Given this list of marker genes YWHAEP7, CCL20, ZNF318 (NCBI Gene Id 24149), CCDC51, RPL34P29, ARHGAP24, POU6F1, DSP, UBE3C, MOGAT3, CSAD, EFNA1, GMNN, TSSC4, CCDC191, METTL25, SLC16A13, FBXO38, SGK1, ZYX, ARHGEF2-AS1, LINC03064, M6PR, PXN-AS1 (PXN antisense RNA 1), SNRPB (small nuclear ribonucleoprotein polypeptides B and B1), EIF4A2, SYBU, COG8, HMGN2P46, PPFIA3, LMO7, LNCRNA-IUR, SNORD2, ZKSCAN2, LDLRAD4, LINC02428, ENO1-AS1 (NCBI Gene Id 100505975), GNG4 (NCBI Gene Id 2786), GPD2, GTPBP3, MMADHC, TTR, SEPTIN2, SESN3, SLC8A1-AS1, BCL9, CCDC28A-AS1, RREB1, LAPTM4A, TMEM217, NDUFS2, CACYBP, FMC1, SUMF2, TIMELESS, ENC1, DDX50, PDGFRB, SWT1, ZBED5-AS1, TOR1AIP1, SLC39A4, C10orf88, SYPL1, WNK4, UBE2D3, TANK-AS1, SIRT6, ZGRF1, LRRC42, MRPS15, SLC25A25, NDUFAF1, CERT1, MIR3912 (NCBI Gene Id 100500831), CCDC59, SCAPER, SNORD49A, ELP6, OCIAD1, AGO3, MTF2, VWC2L, NBPF1, MIR7-3, ALKBH3, SEC23B, PSD4, IP6K2, RPF1, ENSG00000226087, UAP1, TMCO6, SPRED2, SEC31A, SLC13A3, MUC12-AS1, EEPD1, ODAD3, GPX2, KLHDC8B, MRPL20, RXRB, RCN1, SP5, GSTCD, PTRH2 (NCBI Gene Id 51651), PRMT3, GNS, SLC11A2, OAZ2, TANK, POR, GARS1-DT (GARS1 divergent transcript), PNPLA6, PSMA2, NT5C3A, MMP15, C8A, CASC11, VMP1, PTCH1 (NCBI Gene Id 8015), TENT5A, NUS1, PI4K2A, COX19, GATAD2A, TK1, GSTA4, ASGR2, CXXC1, LTBP3, ZNF484, SCARF2, STX18, ELF2 (E74 like ETS transcription factor 2), NFKBIB, HCG20, STX16, SNAP25-AS1, FBXW11, CNOT4, IPO4, EME2, PNO1, FEZF1-AS1, IL1RN, SNAPIN, NFKBIA, TTC32-DT, RBFOX2, PNPLA8, IQGAP1, ENSG00000272195, DUSP6, CDK5RAP1, N6AMT1, NBN, INTS13, MIR5696, SBDS, FTO (FTO alpha-ketoglutarate dependent dioxygenase), DNAJB1, LCAT (lecithin-cholesterol acyltransferase), UNC93B1, NBEAL1, POU6F2, ARSF, UBE2M, ZNF250, TMED4, FUS, PPP2R5E, AADACP1, TBC1D17, PRR14L, KLF5, CCDC126, POLR1F, TNRC18, C3orf38, PRUNE2, PMM2, ZFP91-CNTF, SRC, RPL5, GORASP2 (NCBI Gene Id 26003), MAP3K5, UNK, BRCA1, H4C5, PLEKHA6, RPS7, MIR5707, SCN4A, SPRY1, RAB27B, MRPL44, VNN3P, SSBP1, HMGB1, ABCF3, RUFY1, BDH1, SCAMP2, ESR2, INTS12, MLLT3, DNAI1, RBPJ, CFAP61, HPN, METTL15, ETV4, DAGLB, BBOX1, ZFHX3, PSMA3-AS1, STX16-NPEPL1, DAAM1 (dishevelled associated activator of morphogenesis 1), TRIAP1, NIP7, TAF6L (NCBI Gene Id 55310), FBXO34, NLGN1, UBE2B, GABARAP, DCUN1D4, SLC7A5P2, TBC1D19, ID2-AS1, ZNF594, ATP2B4, SLC7A6 (NCBI Gene Id 9057), ENSG00000235020, CNST, SPCS1, TFG, PDK4, ANLN, ENSG00000273162, MIX23 (NCBI Gene Id 131076), SNRPA1 (NCBI Gene Id 88988), RAB4B-EGLN2, FXYD5, SLC38A6, PHF5A, TFF3, DCTN6, CHMP4B (NCBI Gene Id 60501), ANKS4B, MED13, ADNP, TTI2, FMC1-LUC7L2, NUP153, AFG1L, EIF2AK1P1, SIAH1, RPL39P40, UBE2O, PIWIL2, EPS8L2, RASSF4, RPL8, TRAPPC3, MEIS1 (NCBI Gene Id 4211), LINC02418 (long intergenic non-protein coding RNA 2418), HMGB3P22, SPATA33, CAGE1, GGA1, PHF12, ZFP62, RNF220, CDC73, HERC1, VARS1, MED8, GATA4, ENO1, RNASEH2B, PIP5K1C, POLK (DNA polymerase kappa), WSB2, DCAF11, MRPL57, LINC01124, SSTR5-AS1, CORO7, EVI5, MIGA2, HAL, BLTP2, ZNRD2-DT, PIPOX, FGFR1OP2, WDR38, CTSA, OLFM1, TRIM52-AS1, RAB31, C11orf91, FAM227A, INTS5, OSBP, USP53 (ubiquitin specific peptidase 53), GAPDH, SERPINA11, TOB2, TMEM258, COA5, UGT2A3, THAP7-AS1, MPP1, PDAP1, LINC01703, PPP2R3B, ARID1A, TLE3, COL4A3, CRK, SPAG9, CSTF1, ANGPTL8, MDC1, TMEM18, SFN, WDPCP, CBX1, ANKRD24 (NCBI Gene Id 170961), MIF, PMS1, TBL1X, FAM161A, NCOR1, MTAP, SMIM13, FADS1, LMBR1, AJUBA, CRB1, RNF10, ENSG00000232995, EML6, STAM2, G6PC1 (glucose-6-phosphatase catalytic subunit 1), PCBP2, ZNF335, EXOSC3, ATP6V1D, COMMD1, SLC27A5, PRPF3, MIR4437, ZDHHC12-DT, RPL9P14, TPH2, FITM2, HMGXB3, SFI1, LINC02889, MSX2, UQCRC1, MSH5, EIF4G2, N4BP1, STX3, TIPARP, NCOA3, ATAD3A, PNLIPRP1, TRIM41, BRD2, PEAK1, GPR63, MTSS1, DCAF7, RBM45 (NCBI Gene Id 129831), NBR2 (NCBI Gene Id 10230), FOXN3, ZNF326, CHMP1A, SSTR5, MLH1, UGT2B10, HLA-DMA, LPCAT3, OLA1, TPT1-AS1, TMA7, SH2D6, PPP1CC, ZDHHC6, ZFP91, COG6, TRIB1, EIF2S2P5, UNC50, RPL23, RAB11FIP3, SERPINE1, RER1, HISLA, NRDE2 (NRDE-2, necessary for RNA interference, domain containing), TPT1, ADAP2 (NCBI Gene Id 55803), PIK3R1, DRAIC, RPS15A, TACO1, PEF1, ENSG00000212182, C14orf119, RGN, TMEM18-DT, RNY4P10, ZSCAN29, LUC7L2, AMBRA1, SMARCD2, ACE2-DT, ZDHHC18, DPP9, CFAP74, COQ10B, COX15, SMG1P3, RNU11, STAT6, PPP2R3C, LINC01820, EPS8, ALAS1, TMEM106C, METTL17, SPATA1, MPV17L2, LRIG1, MYH9, DNAAF10, DCXR, MATCAP2, CENPO (centromere protein O), ACE2, KDM4C, ABCC5, HRG-AS1, ASPSCR1, PWWP2A, ARSB, ZBTB38, CIDECP1, RNU4-2, FUT5, EIF2S1, LZTS3, GPATCH11, LINC-PINT, GEMIN8P4, SMG5, NSA2P4, SF3A3, ESYT2, PRORP, USF3, C2, BPHL, METTL13, CAAP1, TRMT1L, CCDC137, SGO2, MPI, KIAA1217, AMACR, USPL1, CALU, SERPINB9P1, SLC13A5, CCNP, ARHGEF1, HILPDA-AS1, FNTB, ZMYM1, EIF2AK4, TBC1D22B, IFTAP, DEAF1, ALDH3A2, RN7SK, GTF3C3, MOSPD3, MZF1-AS1, PSMD3, RNF14 (ring finger protein 14), LINC01144 (long intergenic non-protein coding RNA 1144), MORF4L1, NABP1, WDR25, EEF1AKMT2, TECR, MRM3, LPXN, HK1, PKM, HRG, LINC00216, NFIX, ARHGEF2, HEATR1, PISD, MIR7-3HG (NCBI Gene Id 284424), FARP2, ROCK1, APOF, RIF1, FKBP11, F2RL1, COPS7A, C20orf96, AHI1, LYRM7 (NCBI Gene Id 90624, LYR motif containing 7), FBXO24, GALT, NFE2L2, TMEM39A, HM13, RASA1, TIGD6, SEC22B, NR1D1 (NCBI Gene Id 9572), NR2F1, FAM131B-AS2, ZNF592, MIA2-AS1 (MIA2 antisense RNA 1), CUTC, SDR39U1, KNTC1, RAB4B, CAPZA2, CAMSAP2, AOC4P (amine oxidase copper containing 4, pseudogene), DDX54, RPL13A, DNAJC2, RNF6, FAM3B, GTDC1, ORMDL1, MTMR11, SNX17, ESPL1, GLOD4, KDM3A (NCBI Gene Id 55818), WEE2-AS1, PDE4A, HNRNPD, NFAT5, ALS2CL, DIP2B, HILPDA, CMC2, NDUFAF5, GALNT3 (polypeptide N-acetylgalactosaminyltransferase 3), MPHOSPH9, GPRC5C, MGST2, AHCTF1, MYH9-DT, SRCAP, ENSG00000246308, ZNF106, ORC2, MRPS31, VTN, CCN2, TIGD1, PDK1, SUPT7L, PLXNB1 (plexin B1), CDK2AP2, SMAD3-AS1, TTC32, RBM28, PRKAB2, INHBE, MIR4638, HMGB1P8, ITGB5 (NCBI Gene Id 3693), ESF1, GAR1-DT (NCBI Gene Id 124900758), ENSG00000275765, CCNG2, DDX19B, ADHFE1, LAPTM4A-DT, CGRRF1, RNF19B, DNAJA3, FANCD2, LRRC8E, FAM200A, TCP11L2, ENSG00000270571, LINC00242, BPIFB2, CNOT8, WDR36, MRPS14, RGS20, GLRA1, WDR6, AHI1-DT, SNORD42B, TFF1, COPS2, TIMM22, YIF1A, TARS2, RASSF1-AS1, HTR5A, MAP3K8, SCUBE1, ADAT2, SNAP23, SEH1L, EIF1B, RAPGEF6, NUDT17, DAPK2 (death associated protein kinase 2), TRMT61B, F10, FEZF1, BUD31, TNPO1, PLG (NCBI Gene Id 90749), DCTN6-DT, ENSG00000229425, NBR1, LARP7, GUK1, RFX3-DT, SORT1, MMACHC, HLCS, SARM1, ZNF23, CCDC163, CCDC107, RPLP1, SETD5, TOMM40, IMPA2, ANAPC13, SELENOP, G3BP1, SMG7, CCDC192, RAB5IF, TTC3, NDC1, AKT1S1, PCGF5 (NCBI Gene Id 84333), DDX46 (NCBI Gene Id 9879), TTC27, NXN, AGT, ZNF594-DT, CXCL2, SCFD1, PCIF1 (NCBI Gene Id 63935), H3-3B, FAM186A, EIF1B-AS1, LGMN, HAPSTR1, RPL27, IQCH-AS1, ALDH9A1, TBX15, SLC16A1-AS1, PLD1, GAS5, TESK2, SRSF2, ALG10B, ARMT1, AFP, STAT1, TIPARP-AS1, DDX55, TMEM101, CDKL3, SERINC4, HACD3, C19orf38, NAPA, MDP1, RPL23A, SAE1, THAP7, IDH1-AS1, ZBED5, EXOSC10, ACTMAP, SEMA4C, CHD6, AGAP1-IT1, STAT3, MDH1, COX6A1, A2M, SORBS2, SLC25A23, LINC01977, LIN52, SEC14L5, POLR2H, ACO2, SERPINF1, PTP4A2, COG3, ATXN2L, PCAT14, UTRN, ENSG00000199566, UGT2B25P (NCBI Gene Id 54571), HEG1, RSRP1, SLC25A42, TTLL13, SNRPA, CYP7A1, EXOSC10-AS1, CDK7, TMED1 (NCBI Gene Id 11018), PCK1, THADA, MOB4, WNK1, RAET1K, MASP1, PPP2CA, GDF15, ELMOD3, TBX3, HNMT, CCDC28A, SH2B1, TVP23B, ADK, ZMPSTE24, ZBTB10, SLC4A1AP, RMRP, CCT4, RTTN, PRKCSH, ZNF684 (zinc finger protein 684), ALOXE3, LINC01270, NIBAN3, RBM23, SH3YL1, RASSF1, DCP1A, PHF8, SUN3, MFSD11 (major facilitator superfamily domain containing 11), QTRT2, HAX1, EIF4E2, ZMPSTE24-DT, SLC38A10, ZNF384, RSRC2, PDCD6P1, TUT1, MSH5-SAPCD1, ACSL6, C2CD5, ANKFY1, TEFM, TAF1 (NCBI Gene Id 6872), PSTK, MIA2, CLDN14, ENSG00000241525, PEF1-AS1, ACKR2, RPLP0, LEAP2, ALDH6A1, ZDHHC12, LRCH4, NUP210L, AP1S3, LINC01101, CLIC1, SLC25A12, AKAP9, DSTYK, TBX6, CRNKL1, FZD3, HDLBP, U2AF2, DOCK6, RPGRIP1L, STMN3, ACAT2, ZNF341-AS1, PLK3, PTRHD1, ALG1L1P, ASB1, BLOC1S2, PART1, DMGDH, GLRX, ZNF501, GPRC5D-AS1, CLDN7, CHMP7, NEDD9, PPOX, RMND1, SNORD13, TDRD3, SREBF2, APOA1, PCGF1, IPO11, SORBS3, PARK7, SACS, IPP, CYP2R1, SHFL, TMEM186, USP38, STYK1, GTF2H4, SEPTIN8, NUF2, HMGN2, LUCAT1, NAIF1, PEX3, ENSG00000238142, EIF2B4, RAD51-AS1, ZSCAN9, HYPK, CUL5, SFXN5, IDH1, MIR375, DGKA, PRKCI, CGGBP1 (NCBI Gene Id 8545), BARHL1, ZBTB37, IRS1, HNRNPD-DT, RCL1, GALK2, RNF130, AGPAT1, AHSG, HMG20A, KIAA1328, LTBP1, STK10, ZCCHC8, NCBP2, CENPU, MRPL16, ABCC4, RRS1-DT, SPAG7, SRI, RNU7-27P, TGFBI (NCBI Gene Id 982), SKA3, APOC3, RIOK1, OSBPL6, TBC1D23, KYAT3, C2CD2L (NCBI Gene Id 9854), SLC16A1, LARP1, VARS2, HEATR5A-DT (HEATR5A divergent transcript), LINC02097, NPM1, LGR5, DSP-AS1, ZBTB40, LINC01635, KANSL1, DM1-AS, NIBAN1, ADIPOR2, GANC, NDUFAF4P1, IFT25, AURKA, SLC45A4, SRARP, VTI1A, TMEM87A, MRPS31P5, GRB7, HEATR5B, SF3B5, FLYWCH2, GCHFR, CYB5R4, TRIM44, TUFM, LIAT1, RASSF5, RABGGTA, COX18, GAR1, F2, TF, KAZALD1, TMUB2, RNF111, SEC23A-AS1, AANAT, TYW1, GLT8D1, TMEM52, TFB2M, SZT2, ENSG00000224090, TMEM79, MEP1A, MIR300, RGS5, PCM1, EFL1, AGA, TBC1D8, SNORD118, FNBP1P1, ZCWPW1, SGF29, PPP2CA-DT, UGGT1, VPS51, HUS1, GLTPD2, NRP1, TBC1D9, RFX3, C2orf49, TPRG1L, RBMXL1, GPI, ADH4, HYAL4, DNAJB1P1, HEATR5A (NCBI Gene Id 387979), EPM2AIP1, TMEM267, TNFRSF21, CISD2, CBY1, RAD54B (NCBI Gene Id 730560), AMBP, PARP9, ZNHIT3, CMBL, MRPL32, KLHL9, RNA5SP60, RAB11A, RSPH3, TRIM52, RAD51, C15orf61, ARMC7, PAM16, RETSAT, ELOA, DGAT2, SNRPB2, MRPS34, NEURL4, RNF138, PSMC2, CATSPERG (cation channel sperm associated auxiliary subunit gamma), NLN, DENND4A, GEMIN5, JARID2-AS1, CHCHD2, RPL27A, ZNRD2, METTL3, LDLR, FGA, RNVU1-15, MIR3189, C4BPB, ASB16-AS1, NEURL2, TFRC, ARL6IP6, FBXO33, RCAN1, FBXO34-AS1, TMEM248, NCBP2AS2, DPAGT1, AXIN2, DCXR-DT, MDM4, LINC02410, UGT2B27P, TLE4, MRPS27, MAPK8IP2, LOX, PLPBP, MAGOHB, DHRS11, APOA2, HNRNPA1P30, DMXL2 (Dmx like 2), GATC (NCBI Gene Id 283459), SMG7-AS1, SCRT1, SPECC1, RNF149, C2orf49-DT, SIRT2, DNAJB12, MTRFR, DLC1, KDM8, KRTAP3-1, SLC35A3, LSM8, here is a description of the gene set: species: Homo sapiens from publication Yevshin I, Sharipov R, Kolmykov S, Kondrakhin Y, Kolpakov F (PMID 30445619) Human Gene Set: HHEX_TARGET_GENES Genes containing one or more binding sites for (HHEX) in their promoter regions (TSS -1000,+100 bp) as identified by GTRD version 20.06 ChIP-seq harmonization.